Given this list of marker genes Gja1, Bik, Gmnc, Amh, Foxf2, H3f3b, Srd5a1, Nos3, Gm4787, Ube3a, Bax, Tcf7, Gpr149, Mir183, Neurog1, Casp3, Msh2, Rrm1, Pdgfra, Nr5a2, Sprr2d, Adcyap1, Mir124a-1hg, Cd2ap, Irx5, Rbmyf9, Wnt9b, Asmt, Six4, Dmrt1, Sfrp2, Schip1, Ereg, Tcf21, Hsd17b4, Rbmyf5, Mir182, Adam24, Zfpm2, Nanog, Ybx3, Foxc1, Immp2l, Ptx3, Cebpb, Nefh, Lrp6, Ahr, Csmd1, Osr1, Tiparp, Safb2, Adam15, Pla2g4a, Nr0b1, Hnf1b, Smad9, Adam6a, Notch1, Ubb, Ror2, Tnfaip6, Gdf9, Axl, Spata2, Grk2, Ermp1, Cntfr, Fzd4 (frizzled class receptor 4), Tbc1d20, Bmpr1a, Bak1, Hnrnpk, Arrb1, Dnajc19-ps, Fancg, Mir881, Dhx37, Ccdc182, Adam29, Rec8, Mir455, Mir202, Tex19.2, Ptprn, Star, Sirt1, Kit, Bok, Dnaaf3, Dmrta1, Adamts1 (NCBI Gene Id 11504, ADAM metallopeptidase with thrombospondin type 1 motif 1), Mir184, Sfrp1, Ago4, Tgfb2, Tesc, Lep, Serpine1, Adam1b, Gfra1, Ccnd1, Dach1, Lhx1, Dmrt3, Adam2, Ace, Wdr19, Fgf9, Zfx, Six3, Adam30, Tnfsf10, Adam34, Crkl, Eif2b5, Insl3, Tbx3, Bcas2, Zfp830, Hnf4a, Nipbl, Ctnna1, Mir878, Kcne1, Rdh10, Nobox, Afp, Npr2, Mir135a-2, Casp2, Adam25, Bcl2l11, Pbx1, Mmp14, Spo11, Tlr3, Ercc1, Sry, Itgav, Lhfpl2, Jmjd1c, Nrip1, Rara, Stat5b, Lgr4, Tmf1, Ncoa1, Lhb, Hoxa13, Edn2, Asb1, Greb1l, Rbmyf6, Fer, Tgfbr1, Ccno, Sycp2, Mir135a-1, Ptpn11, Rxfp2, Mir743, Runx1, Cftr, Adam34l, Adam26b, Angpt1, Vegfa, Mir138-1, 2610005L07Rik, Aspm, Pde4d, Retn, Rhobtb3, Arid4b, Bcl2l1, Adrm1, Hmgb2, Nudt1, Ctnnb1, Bmp5, Mmp19, Rbmyf1, Adam4, Cyp19a1 (NCBI Gene Id 13075), Cbl, Bmp4, Sgpl1, Mir144, Idh1, Eif2b2, Adam3, Eif2s3y, Adam39, Sema3a, Mfn2, Plekha1, Mir742, Zp3, Lhx8, Fance, Mir471, Rbmyf7, Taf4, Rab13, Rac1, Fgf8, Spink2, Kitl, Gata6, Atrx, Mir138-2, Smad4, Tyro3, Ahsg, Adam18, Mcidas, Insl6, Adam26a, Adam6b, Fgf7, Sohlh2, Dmrt2, Odad3, Wnt4, Mamld1, Tcf7l2, Cited2, Adgrg1, Inhbb, Bmpr1b, Fndc3a, Hoxa9, Nppc, Gata4, Ctsl, Hoxd13 (homeobox D13), Fanca, Pitx2, A2m, Pkd1, Inhba, Ptger4 (prostaglandin E receptor 4 (subtype EP4)), Rbmyf8, Myh9, Hmga2, Arid4a, Adam20, Dnaaf11, Msh4, Inha, Foxl2 (NCBI Gene Id 26927), Akap9, Bcl2l2, Brip1, Cga, Tex15, Gas2, Il1a, Mir96, Vgf, Mir124-2hg, Dhh, Fancf, Klhl10, Kmt2b, Scaper, Nr5a1, Wdr48, Wnt5a, Agt, Tifab, Tex19.1, Adam5, Trp63, Nhlh2, Mas1, Rbp4, Fshr, Fst, Sf1, Nkx3-1, Fshb, Phb1, Dmrtc2, Bmp6 (bone morphogenetic protein 6), Umodl1, Lfng, Sox2, Ren1 (renin 1 structural), Sohlh1, Wnt2b, Serpinb6a, Bcl2, Atn1, Ntrk1, Rnase10, Gata1, Kdr, Esr2, Sox3, Amhr2, Kdm5a, Fkbp4, Adam21, Cbx2, Dhcr24, Oas1d, Esr1, Acvr2a, Hoxa11, Lrp2, Mir880, Abcb1a, Lhcgr, Adam1a, Flna, Eif2b4, Mir193a, Tsx, Dach2, Dnajc19, Hesx1, Rbmyf2, Pgr, Nup107, Sdc1, Icam1, Patz1, Tex11, Srd5a2, Arrb2, Nupr1 (NCBI Gene Id 80556, nuclear protein transcription regulator 1), Gata3, Tfpt, Brca2, Sox8, Slit3, Sod1, Atm, Cyp1b1, Nkx2-1, Rad21l, Mir741, Dmc1, Smad5, Wt1, Nup210l, Stra6, Hoxa10, Adam32, Ar, Foxo3, Ing2, Mmp2, Lhx9, Dmrta2, Arid5b, Prdx4, Src, Mertk, Sox9 (SRY (sex determining region Y)-box 9), Scx, Gm17266, Insr, Shh, Nr2f2, Pcyt1b, Nos2, Rbmyf3, Fgf10, Stat5a, Gnrh1, Map7, Hyal3, Mir672, Dmrtb1, Kif18a, Tlr9, Rbmy, Lsm14b, Eif2s2, Chd7, here is a description of the gene set: studied in species Mus musculus Mouse Gene Set: GOBP_SEX_DIFFERENTIATION The establishment of the sex of an organism by physical differentiation.